Given this list of marker genes CASP6, BIRC2, XIAP, TNFRSF1A, CASP10 (NCBI Gene Id 843), TNF, CASP3, TRAF2, CRADD, PIDD1, SREBF1, TRADD (NCBI Gene Id 8717), RIPK1, PRF1, CASP4, LMNB2, TFAP2A, APP, BIRC3, APAF1, TOP1, CFL2, DFFB, SPTAN1, GSN, CASP7, SATB1, MADD (MAP kinase activating death domain), LIMK1, NUMA1, ARHGDIB, DIABLO, CASP9, PTK2, DFFA, LMNB1, BAX, KRT18, PARP1, BID, CASP1, GZMB, CASP2, CASP8, ACTA1, BCL2, LMNA, VIM, GAS2, CYCS, MAP3K1, here is a description of the gene set: Human Gene Set: PID_CASPASE_PATHWAY species: Homo sapiens from publication Schaefer CF, Anthony K, Krupa S, Buchoff J, Day M, Hannay T, Buetow KH (PMID 18832364) Caspase cascade in apoptosis